The following is a description of a gene set: A history of repeated acute infections of the upper or lower respiratory tract. studied in species Homo sapiens Recurrent acute respiratory tract infection Human Gene Set: HP_RECURRENT_ACUTE_RESPIRATORY_TRACT_INFECTION, and this is the list of marker genes: PLCG2, KMT2D, ALDH18A1, SDCCAG8, SLC35C1, REEP1, KDM6A, FBLN5, PLEC, GBA1, TAP1, ELN